The following is a description of a gene set: species: Mus musculus Any process that results in a change in state or activity of a cell (in terms of movement, secretion, enzyme production, gene expression, etc.) as a result of a peptidoglycan stimulus. Peptidoglycan is a bacterial cell wall macromolecule. Mouse Gene Set: GOBP_CELLULAR_RESPONSE_TO_PEPTIDOGLYCAN, and this is the list of marker genes: Defb25, Nod2, Trem2, Nlrp3 (NLR family, pyrin domain containing 3), Ripk2, Rela, Tlr2, Camp